Given this list of marker genes mt-Cytb, Sdhd, Ptpmt1, Cox7a2l, Trap1, Mrpl4, Letm1, Mrpl48, Cox6c, Sco2, Atp5pd, Fpgs (folylpolyglutamyl synthetase), Hsd3b3, Timm8b, Cox8c, Slc25a23, Nemp2, Nemp1, Abca12, Tmpo, Mrpl34, Mrps28, Rnf13, Stoml2, Glud1 (glutamate dehydrogenase 1), Cyp11a1, Aifm3, Slc25a31, Mrpl17, Mrpl57, Ndufc1, Tor1aip1, Tmem14c, Sirt5, Gadd45gip1, Micos13, Ak2, Mrpl50, Atp5po, Ndufs7, Mrps31, Ndufb3, Ndufs6, Ndufv3 (NADH:ubiquinone oxidoreductase core subunit V3), Cox6b1, Slc8b1, Ugt1a6a (UDP glucuronosyltransferase 1 family, polypeptide A6A), Ndufs5, Ndufaf3, Vdac3, Sdhb, Letmd1, Oxa1l, Cox6a1, Mrps6, Ndufb1, Mrps23, mt-Co3, Atp5f1c (NCBI Gene Id 80670), Rcc1l, Acaa2, Hspd1, Ndufs8, Cox6b2, Ndufs2, Psen2, Cox7c, Mtch2, Sun1 (NCBI Gene Id 77053), Mrps12, Coq10b, mt-Nd4, Nipsnap1, Mcub, Apool, Atp5pf, Sfxn5, Slc25a48, Mrpl55, Pet100, Sun3, Atp5pb, Ndufb4, Coq2, Cpt1a, Ndufs1, Tmem256, Mrpl42, Nutf2, Chchd10, Mrps25, Fahd1, Lbr, Timm8a2, Mrpl15, Unc50, Micu2, Mrpl19, Ndufab1-ps, Sphk2, Tmem70, Uqcrb, Gcdh, mt-Nd5, Mpv17, Mcu, Atpaf2, Ptgs2, Mrpl3, Cox7b2, Clu, Slc25a21, Ndufb8, Sirt3, Ldhd, Mpv17l2, Atp5f1d, Mtfp1, Ndufs6b, Mrpl12, Phb1, Ccdc51, Slc25a16, Mrps14, Slc1a3, Mpst, Cox20, Ndufv2, Mrpl28, Fdx1, Lyn, Ifi27l2b, Ndufa3, Ambp, Slc25a22, Hccs, Herc2, Atp5f1a, Tm7sf2, Tra2b, Coq5, Abcb7, mt-Co1, Mrpl53, Hsd3b2 (hydroxy-delta-5-steroid dehydrogenase, 3 beta- and steroid delta-isomerase 2), Abcb10, Cyb5b, Iffo1, Gstk1, Sfxn1, Mrpl33, Ifi27l2a, Tmem120a, Cox6a2, Dhrs1, Mrpl51, Acat1, Coq4, Ndufa4, Slc3a1, Spag4, Slc25a51, Alas2, Slc25a47, Prodh2, Dusp18, Cps1, Them4, Mthfd2l, Cyp1a1, Ociad2, Ppif, Slc25a42, Kcnk9, Uqcrh-ps1, Maip1, Mrps16, Endog, Mccc1, Gpd2, Ndufb7, Chchd6, Slc25a1, Slc25a19, Tafazzin, Slc25a13, Cox7a2, Mrps27, Atad3a, Cav2, Immp1l, Hsd3b1, Acadvl, Dmac2l, Mrpl38, Immt, Slc25a27, Coq3, Idh2, Ndufa11b, Rsad2, Spg7, Sfxn3, Timm9, Rdh13, Sfxn4, Ndufa8, Mrpl13, Cox4i2, Got2, Slc25a38, Mrpl37, Cabs1, Chchd1, Sod2, Mrps7, Guf1, Mrps5, Coq9, Coa3, Eral1, Cox8b, Mrps10, Nat8f1, Mtx1, Nme6, Pde2a, Ucp3, Tmem223, Timm10b, Ndufb9, Mrpl16, Slc25a5, Acad9, Slc25a4, Maob, Sirt4, Mtnap1, Ghitm, Neu4, Sigmar1, Stat3, Ptcd3, Cyp2u1, Slc41a3, Mtarc2, Immp2l, mt-Co2, Prodh, Tst, Hsd3b5, Rab5if, Mtarc1, Slc27a1, Afg3l1, Slc25a37, Ckmt2, Timm21, Timm50, Srgap2, Tufm, Aurkaip1, Samm50, Mrps2, Ucp1, Snca, Uqcc6, Dele1, Cox15, Cnp, Lgals3, Arl6ip6, Sun2, Micos10, Ndufb4c, Mrpl22, Sqor, Coq7, mt-Nd4l, Cpox, Slc25a25 (NCBI Gene Id 68663), Uqcc5 (ubiquinol-cytochrome c reductase complex assembly factor 5), Slc25a43, P2rx6, Ndufb11b (NADH:ubiquinone oxidoreductase subunit B11B), Eci1, Cyp2b10, Cox11 (NCBI Gene Id 69802), Cox5a, Hmgcl, Pgam5, Trmt10b, Tmem242, Ndufb5, Aldh3a2, Ndufa1, Dhodh, Hadhb (NCBI Gene Id 93764), Cyp27a1, Dnajc11, Ndufb11, Slc25a28, Gpam, Tmem11 (NCBI Gene Id 216821), Atp5mg, Slc25a12, Mrpl21, Ndufb10, Hsd3b6, Sdha, Uqcc3, Smpd5, Mrpl11, Kmo, Sfxn2, Fam209, Pmpcb, Tyms, Uqcrc1, Slc22a14, Hadha, Tmem43, Mrpl20, Ndufb4b (NCBI Gene Id 100042503), Mfn1, Mrpl23, Mrpl9, Aifm1, Slc25a30, Pink1 (PTEN induced putative kinase 1), Mcur1, Akap1, Terb2, Ndufa7, Tmem177, Micu1 (NCBI Gene Id 216001), Aqp8, Higd1a, Mrpl39, Mrps26, Slc25a10, Hadh, Grpel1, Ppox, Mpc1, Pcx, Mtg2, Mrpl32, Ndufs4, Rps3, Cox7a1, Mrps33, Coq8a, Mrpl45, Ldhb, Cyc1, Timm17a (NCBI Gene Id 21854), Pam16, Mrps30, Smad3, Slc25a44, Mrs2, Slc25a26, Star, Plscr3, Parl, Myoc, Ndufa10, Mtg1, Mrps34, Efhd1 (NCBI Gene Id 98363), Otc, Aldh18a1, Pla2g4b, Dpy19l2, Mrps24, Mrpl27, Mrpl44, Coa8, Slc25a3, Bcl2, mt-Nd2 (mitochondrially encoded NADH dehydrogenase 2), Atp5f1e, Ndufb2, Alas1, Mrpl41, Smad1, Phb2, Agk, Csde1, Mtln, Exog, Noa1, Cpt2, Emd, Bdnf, Cyp2e1, Mrpl58, Tomm22, Ndufa5, Pisd, Fam169a, Atp5mk, Timm8a1, Tmem65, Slc25a11, Timm44, Uqcc2, Clpx, Cyp11b1, Dnajc30, Cox4i1, Cox8a, Cyb5r3, Letm2, Abcd3, Ndufa2, Atp5mf, Slc25a29, Timm23, Atpaf1, Yme1l1, Uqcc1, Ndufaf5, mt-Atp6, Ndufs3, Timm22, Slc25a14, Slc25a15, Mrps18a, Timm13, Mgst1, Cox5b, Abca8b, Cox7b, Mrps18b, Atp5mc1, Rhot2, Tamm41, Mgarp, Uqcrh, Cox18, Nrm, Atp5f1b, Slc25a39, Apoo, Afg3l2, Tk2, Dusp21, Mrpl10, Tmem120b, Src, Pdss1, Ndufv1, Mdh2, mt-Nd6, Pdk4, Gpx4, Cox16, Sdhc (succinate dehydrogenase complex, subunit C, integral membrane protein), Slc25a33, Hmgcs2, Majin, Itpr1, Etfdh, Coq6, mt-Nd3, Slc25a20, Uqcr10, Bcl2l1 (BCL2-like 1), Smim20, Grpel2, Hsd3b8, Mrpl54, Ptpn1, Mrps11, Fech, Mfsd10, Higd2a, Ndufa11, Ern1, Mrpl24 (NCBI Gene Id 99473), Bok, Bcs1l (NCBI Gene Id 66821), Ndufa12, Fdxr, Acsl5, Mrpl35, Timm29, Uqcrfs1, mt-Nd1, Mrps18c, Tmem201, Dnajc15, Mrpl2, Lemd3, Mrpl36, Ndufaf6, Apex2, Ndufb6, Mrpl46, Ghrhr, Dap3, Stmp1, Dhfr, Mrpl14, Sirt1 (sirtuin 1), Terb1, Capn10, Slc25a18, Dmac1, Oma1, Psen1, Mrpl52, Ndufc2, Mrpl40, Micu3, Smdt1, Tmem160, Atp5me, Mrpl30, Tmem126a, Romo1, Mrps22, Hsd3b9, Ckmt1, Mrps35, Lrpprc, Slc25a32, Opa1, Pmpca, Plpp6, Suclg1, Timm17b, Ttc19, Ndufa6, Ucp2, Mrpl1, Mrpl47 (mitochondrial ribosomal protein L47), Lrrk2, Mpc2, Ifi27, Vdac2, Cibar1, Foxred1, Slc25a40, Hsd3b4, Fgr, Slc25a45, Slc25a35, Mrpl18 (mitochondrial ribosomal protein L18), Uqcrq, Vdac1, Timm10, Crat, Lemd2, Gcat, Chdh, Kcnh1, Ndufa9, Tmx4, Abcb8, Bdh1 (NCBI Gene Id 71911), Polg, Mrpl43, Mrps21, Uqcr11 (ubiquinol-cytochrome c reductase, complex III subunit XI), Crls1, Slc30a2, Ndufa13, Slc25a24, Uqcrc2, Mrps15, Lmnb1, Atpsckmt, Mrpl49, Sco1, Tomm40, Slc25a36, Mrps9, Ugt2b37, Ndufab1, Shmt2, Cyp11b2, Bckdhb, Dnajc19, Tmem186, Chchd3, Sun5, Adck1, Twnk, Mrps17, Ugt2b5, Uqcc4, Zmpste24, Dmd, Nnt, Slc25a41, Pdss2, Atp1b4, Slc25a34, Hsd17b10, Gatm, here is a description of the gene set: Mouse Gene Set: GOCC_ORGANELLE_INNER_MEMBRANE The inner, i.e. lumen-facing, lipid bilayer of an organelle envelope; usually highly selective to most ions and metabolites. species: Mus musculus